Given this list of marker genes Gnmt, Sema6a, Tmem140, Tspan13, Ly6c1, Rassf9, Nrp1, Lap3 (leucine aminopeptidase 3), Ttll7, 1700019D03Rik, Spock2, Ccser1 (NCBI Gene Id 546258), Abcg2, Lcorl, Pde9a, Cpeb3, Ntrk2, Parva, Bcl2l11, Add3, Dnm3, Olig1, Fkbp5, Anapc16, Pmm1, Fzd1, Gulp1, Tfap2e, Nr3c1, Acot6 (NCBI Gene Id 74037), Ednra, P4ha2, Flg, St6gal1, Scrg1, Hpgd, Asb7, Megf6, Ccdc71l, Reck, Iqgap2, Stc2, Rab11fip5, Sulf2, Zfp119b, Itpr1, Rrm2, Myb, Il17rb, Galnt15, Spink2, Slc43a2, Kctd14, Trak1, Trib2, Col19a1, Nt5dc2, Best2, Tgfb3, Zbtb16, Scnn1g, Ndrg2, Ttc28, Cyp27a1, Chd9, Slc26a6, Tnfrsf21, Ifit2, Ramp3, Ddit4l, Atp1a1, Mgat4a, Serpinb3c, Fxyd4, Dock5, Zfp52, Cmah, Enpp1, Pdgfra (NCBI Gene Id 231312), Ednrb, here is a description of the gene set: Mouse Gene Set: CHEBOTAEV_GR_TARGETS_UP Glucocorticoids are potent inhibitors of mouse skin tumorigenesis. The glucocorticoid control of cellular functions is mediated via the glucocorticoid receptor (GR), a well-known transcription factor. Recently, we generated transgenic mice overexpressing GR under control of the keratin5 (K5) promoter, and showed that K5.GR animals are resistant to skin carcinogenesis. Follicular epithelial stem cells (SCs), located in the bulge region of the hair follicle, are believed to be one of the target cells for skin carcinogenesis. We found that the number of putative hair follicle SC detected as label-retaining cells was significantly less in the K5.GR transgenics compared to wild type (w.t.) littermates. We also showed that GR overexpression led to a reduction in the clonogenicity of the follicular epithelial SCs. We evaluated the global effect of GR on gene expression in a population of follicular SC-enriched bulge keratinocytes isolated by fluorescence activated cell sorting. We found that GR affected the expression of numerous bulge SC 'signature' genes, genes involved in the maintenance of SC and progenitor cells of non-epidermal origin and proapoptotic genes. Our findings underscore the important role of GR signaling in the homeostasis of follicular epithelial SCs, and suggest that the reduction in their number may underlie the tumor suppressor effect of GR in the skin. Genes up-regulated in follicular epithelial stem cells after transgenic expression of GR under control of the keratin5 (K5) promoter. species: Mus musculus from publication Chebotaev D, Yemelyanov A, Zhu L, Lavker RM, Budunova I (PMID 17146443)